Given this list of marker genes NCLN, NOMO1, SMO, FOXH1 (NCBI Gene Id 8928), SHH, SMAD2, NOMO3, NODAL, DAND5, CITED2, here is a description of the gene set: Human Gene Set: GOBP_DETERMINATION_OF_LEFT_RIGHT_ASYMMETRY_IN_LATERAL_MESODERM The establishment of the lateral mesoderm with respect to the left and right halves. studied in species Homo sapiens